The following is a description of a gene set: studied in species Homo sapiens Human Gene Set: GOMF_RECEPTOR_TYROSINE_KINASE_BINDING Binding to a receptor that possesses protein tyrosine kinase activity., and this is the list of marker genes: CRKL, RNF41, CRK, PCNA, ACP4, TP53, EIF3A, FLT3LG, SQSTM1, DOK2, PITPNM1, RACK1, GRB2, PITPNM2, TRADD, NRG1, ANGPT1, PITPNM3, ARTN, YWHAG, CD2, GDNF, SHC2, MYOC, STAP1, DGKQ, SH2B3, ALKAL1, IRS2, DUSP3, PIK3R1, SOCS5, ANGPT2, GFRAL, GAB4, GAB2, CADM4, MST1L, GAS6, CBL, LRP4, ALKAL2, SH2B1, PTPN2, SHC4, CBLB, NRG3, GRB14, PIK3R2, ANGPT4, ERBB2, FIZ1, SH2B2, NCK2, ITGAX, FNTA, TOB1, CBLC, FRS3, TRAT1, PTPN1, BLNK, ARHGEF16, CPNE3, ELMO2, PTPN14, NRTN, PTPN11, FRS2, GRAPL, DAZAP2, IRS1, NCK1, PSPN, SHC3, HYAL2 (NCBI Gene Id 8692), SHC1, ZPR1, MST1, DOCK4, MAP3K7